The following is a description of a gene set: The chemical reactions and pathways involving heme a, a derivative of heme found in cytochrome aa3. Human Gene Set: GOBP_HEME_A_METABOLIC_PROCESS species: Homo sapiens, and this is the list of marker genes: ALAS1, COX10, COX15, UROD, CPOX (coproporphyrinogen oxidase), HMBS, ALAD, UROS, FECH, PPOX